The following is a description of a gene set: Human Gene Set: LAKE_ADULT_KIDNEY_C13_THICK_ASCENDING_LIMB from publication Lake BB, Chen S, Hoshi M, Plongthongkum N, Salamon D, Knoten A, Vijayan A, Venkatesh R, Kim EH, Gao D, Gaut J, Zhang K, Jain S (PMID 31249312) studied in species Homo sapiens, and this is the list of marker genes: CYFIP2, PDE1A, BCAS3, SKAP1, CLCN5, PRKD1, HIP1, COBLL1, NHS, ERBB4, FGD4, FBXL17, RHOBTB3, PTGER3, TAPT1-AS1, OSBPL3, ADAMTS9-AS2, PCCA, TNRC6A, TACC1, SLC16A12, KANSL1, UMOD, BICDL1, ARHGAP24, SLC4A7, CCDC148, PHACTR1, TBCK, EGF, PKP4, TMEM161B-DT, MAML2, PTH2R, IMMP2L, KCNIP4, DOCK1, GMDS-DT, EFNA5, MECOM, ARHGAP6, STK32B, SNHG14, BRAF, LINC01606, PRKN, TRIM2, DANT2, SSBP2, KCNJ16, GALNT18, NR3C2, MYO9A, WNK1, CASR (NCBI Gene Id 846), OXR1, CLCNKB, ATP1A1, HIBADH, FAF1, ESRRG, ZHX3, CPEB4, RNF150, BABAM2, PPARGC1A, GPC5 (NCBI Gene Id 2262), CACNA2D3, VAV3, USP53, KLF12, RANBP3L, LAMB1, IGF1R, PLCB1 (NCBI Gene Id 23236), AUH, RNPC3, STXBP4, NELL1, FHIT, LRBA, NAALADL2, CA12, SGIP1, WWOX, COL4A3, KNG1, USP25, PLCL1, MSI2 (NCBI Gene Id 124540), ATP1B1, CCSER1, TBC1D4, DYNC2I1, CA10, NR2F2-AS1, DPH6, PBX1, WWC2, PKHD1, VWA8 (von Willebrand factor A domain containing 8), NCOA2, LRP1B, AK3, MACROD2, AGBL4, SULT1C2, PCDH9, TFCP2L1, DDX17, SOX6, KLHL13, SLC12A1, PNISR, PDE7B, ABLIM1, CLMN, THRB, KIAA1217, ANKRD26, ENOX1, FKBP5, ADK, ANK2, SCHLAP1 (NCBI Gene Id 101669767), LINC00970, PTPN4, LGR4, FOXP2, DNAH14, CGNL1